Given this list of marker genes Acat2, Cyp8b1, Prap1, Enpp7, Lpcat3, here is a description of the gene set: studied in species Mus musculus Any process that activates or increases the frequency, rate or extent of intestinal absorption. Mouse Gene Set: GOBP_POSITIVE_REGULATION_OF_INTESTINAL_ABSORPTION